Given this list of marker genes ETV3, TBR1, ATF6B, AMELY, GPLD1, CLUL1, CBS, SMCP, PAH, PCK1, LEPR, CBLN1, CEACAM7, SERPINB3, ZIC1, RGS7, HOXB3 (homeobox B3), WNT5A, ELL, TBX2, OPCML, TIAM1, ST6GALNAC2, ASGR2, KCNB1, PDCD2, HSD17B2, MMP8, CADPS, MAOA, FGFR3, NAP1L3, ITGA3, ATP2B2, MAP2, HRH1, HNF4A, FLT1, THRB, PIK3CD, ZKSCAN7 (NCBI Gene Id 80241), GMPR, EFNB3, HAS2, GP5, RREB1, DMD, DNASE1L3, DRD4, CYP2C9, SERPINA6, GPM6A, PLA2G2A, CENPE, FLT4, TACR3, NR1I3, GCG, OMG, CHN2, DPP6, MYF6, GPA33, PROZ, PRKCA, CLCN4, IL3, GHR, KRT76, MAG, ALDH6A1, NOVA1, GAP43, CRABP1, HRG, CYP3A7, SLC6A4, AR, KCNN3, APLP1, MYB, PTPRO, GAD1, UMOD, ENPEP, MIR9-1HG, SPTB, AMPD1, RGR, FHL3, ZNF157, ALAD, ABO, CRMP1 (NCBI Gene Id 1400), ANGPT1, NR1D1 (NCBI Gene Id 9572), CTF1, KRT86, WNT2, CHRNA4, GLP1R, GAGE1, KIR2DL3, DLG4, RASL10A, ATP1B2 (NCBI Gene Id 482), RRH, here is a description of the gene set: Genes in the cancer module 113. Human Gene Set: MODULE_113 species: Homo sapiens